The following is a description of a gene set: Mouse Gene Set: GOBP_KERATAN_SULFATE_PROTEOGLYCAN_METABOLIC_PROCESS species: Mus musculus The chemical reactions and pathways involving keratan sulfate proteoglycans, which consist of a core protein linked to a keratan sulfate glycosaminoglycan. The keratan sulfate chain is composed of the repeating disaccharide unit beta-(1,4)-N-acetyl-D-glucosamine-beta-(1,3)-galactose, both of which can be sulfated., and this is the list of marker genes: Glb1, B3gnt7, Gns, Chst1, Chst5, B4galt4